Given this list of marker genes Mir7-2, Cdh1, Ptk6, Sox9, Hoxa5, Cbfa2t2, Fzd5, Hif1a, Nkx3-2, Sav1, Tyms, Gata4, Gata6, Tigar, Dicer1, Gata5, Tmigd1 (transmembrane and immunoglobulin domain containing 1), Il6st, Cdx2, Prdm1, Cdkn1a, Klf5, Mir203, C1galt1, Gsdmc2, Yipf6, Tlr9, Src, Yap1, Mir7-1, Spdef, here is a description of the gene set: The process in which a relatively unspecialized cell acquires specialized features of a columnar/cuboidal epithelial cell of the intestine. Mouse Gene Set: GOBP_INTESTINAL_EPITHELIAL_CELL_DIFFERENTIATION species: Mus musculus